Given this list of marker genes Azin2, Oaz1, Azin1, Oaz2, Oaz3, here is a description of the gene set: Mouse Gene Set: GOMF_ORNITHINE_DECARBOXYLASE_REGULATOR_ACTIVITY Binds to and modulates the activity of the enzyme ornithine decarboxylase. species: Mus musculus